Given this list of marker genes Plaur (plasminogen activator, urokinase receptor), Pigs, Pigt, here is a description of the gene set: This event has been computationally inferred from an event that has been demonstrated in another species.<p>The inference is based on the homology mapping from PANTHER. Briefly, reactions for which all involved PhysicalEntities (in input, output and catalyst) have a mapped orthologue/paralogue (for complexes at least 75% of components must have a mapping) are inferred to the other species. part of: Post-translational modification: synthesis of GPI-anchored proteins studied in species Mus musculus Reactome Pathway: Attachment of GPI anchor to uPAR electronically inferred by orthology from the curated human pathway